Given this list of marker genes CDC20, UGT2B17, TPD52L1, SLC26A2, CEP55, SLC7A5, CCNA2, HMGB2, PPM1E, KCNK5, FAM83D, SIAH2 (NCBI Gene Id 6478), CXCL12, OLFM1 (NCBI Gene Id 22825), IL20, THBS1, TFF1, IGFBP4, PKIB, ITPK1, TUBA4A, WDR62, GREB1, HSPB8, BUB1, RNASEH2A, here is a description of the gene set: from publication Williams C, Edvardsson K, Lewandowski SA, Ström A, Gustafsson JA (PMID 17700529) Human Gene Set: WILLIAMS_ESR1_TARGETS_UP The 'ER-alpha profile': genes up-regulated in T47D cells (breast cancer, ESR2 Tet-Off) upon activation of ESR1 by estradiol (E2). studied in species Homo sapiens Transcriptional effects of estrogen result from its activation of two estrogen receptor (ER) isoforms; ERalpha that drives proliferation and ERbeta that is antiproliferative. Expression of ERbeta in xenograft tumors from the T47D breast cancer cell line reduces tumor growth and angiogenesis. If ERbeta can halt tumor growth, its introduction into cancers may be a novel therapeutic approach to the treatment of estrogen-responsive cancers. To assess the complete impact of ERbeta on transcription, we have made a full transcriptome analysis of ERalpha- and ERbeta-mediated gene regulation in T47D cell line with Tet-Off regulated ERbeta expression. Of the genes and transcripts analysed, 4.1% (1434) were altered by ERalpha activation. Tet withdrawal and subsequent ERbeta expression inhibited the ERalpha regulation of genes and, in addition, altered expression of 152 non-ERalpha-regulated genes. ERalpha-induced and ERbeta-repressed genes were involved in proliferation, steroid/xenobiotic metabolism and ion transport. The ERbeta repressive effect was further confirmed by proliferation assays, where ERbeta was shown to completely oppose the ERalpha-E2 induced proliferation. Additional analysis of ERbeta with a mutated DNA-binding domain revealed that this mutant, at least for a quantity of genes, antagonizes ERalpha even more strongly than ERbeta wt. From an examination of the genes regulated by ERalpha and ERbeta, we suggest that introduction of ERbeta may be an alternative therapeutic approach to the treatment of certain cancers.